Given this list of marker genes Npm1, Brcc3, Ppp6c, Psmd8, Rcc2, Ubc, Nup205, Cdkn1a, Plk4, Kntc1, Mau2, Pole4, Abraxas1, Dynll1, Dync1i1, Nup93, Cenpx, Gtse1, H2bc6, Cep250, Ppp1r12a, Pola2, Cdc45, Terf2, Tubgcp5, Nup153, Anapc1, Haus8, Nup133, Brca1, Smc3, Vrk1, Psmd2, Gins1, H2ac7, Fbxo5, Ube2c, H2bc8, Incenp, Ccna2, Mcm8, Nup58, Dscc1, Kif2a, Pttg1, Rbl1, Nup155, Cenpi, Ran, Terf2ip, Hmmr (hyaluronan mediated motility receptor (RHAMM)), Prim1, Taok1, Psma3, Tubb1 (NCBI Gene Id 72817), Prkaca, Cdc25b, Haus6, Tubb6, Nme7, H4c17, Haus5, Nup62, Tert, Smarca5, H2ac12, Ofd1, H2ac18, Nup85, Bub3, Ncapg, H2ac19, Cdc16, Cep70, Mdm4, H3c7, Cks1b, Nudc, Cdc26, Dync1h1, Ppp2r5e, Pds5b, Cep63, H2bc21, Fbxl18, Ppp2r2a, Gorasp2, Rfc3, Hdac8, Cdc7, H3f3b, Anapc2, H2ac6, Nup43, H4c8, Cdca5, Ska2, Cep57, Cdc27, Haus7, Cables1, Psmc4, Cenpe, Tuba3a (tubulin, alpha 3A), Nup98, Cenpw, Ube2e1, H4c2, Eml4, Kif18a, Ccna1, Wapl, Psmc5, Aurka, Wee1, Rfc5, Cenph, Ccnb1, Nup214, Brip1, Clspn, Mapk3, H2bc26, Lpin2, Hdac1, Ywhag, Nek9, Kif2c, Phf20, H2aj, Mis12, Ppp2r5c, Nup42, Exo1, Aurkb, H2ac20, Anapc15, Hsp90ab1, Csnk2a2 (NCBI Gene Id 97446), Zw10, H2ax, Ppp2r1a, H3c15, Ist1, Cdc6, Ccnb2, Skp2, Ckap5, Nhp2, Terf1, Herc2, Cenpu, Cep131, Mcm2, H2ab3, Dync1i2, Fkbpl, Cep72, Cdk1, Haus1, Ccnd1, Mcm3, Banf1, Lin54 (lin-54 DREAM MuvB core complex component), Ubb, Fbxl7, Seh1l, Rbx1, Wrn (NCBI Gene Id 22427), Cdk2, Rfc4, Zwint, Mcm5, Ube2d1, Cetn2, Psmd7, Ndel1, E2f2, Cenpc1, Rnf8, Ranbp2, Rtel1, Rbbp7, Akt2, H2bc12, Pias4, Ccp110, H2bc22, Rb1, Pold4, H2bc24, Rmi1, Pole, Chek1, Pold1, Ppp2ca, Lmnb1, Psmd12, Atrip, Uba52, Csnk2b, Rbbp8, Abl1 (NCBI Gene Id 98922), Mis18bp1, Akt3, Chmp3, Pkmyt1, Psmd3, H3c6, Akt1, Psma5, Anapc16, Orc6, Psma6, Chmp2b, Vps4a, Spast, E2f3, Tuba1a, Orc5, Skp1 (NCBI Gene Id 76591), Cenpp, Tpr, Esco2, H3c4, Psma1, Rad9b, Rab1a, Anapc5, Tubgcp6, Oip5, Ppp2r5a, H2ac15 (H2A clustered histone 15), Cnep1r1, Sfn, Haus2, Fbxw11, H3c3, H3c13, Ahctf1, Mcm10, Ppp2r1b, Rfc1, H2ac4, Nup107, Ncapd3, H2bc4, Ankle2, Ten1, H4c18, Gmnn, Tubg2, Nup37, Lbr, Nsl1, Ube2n, Rfc2, Obi1 (NCBI Gene Id 72486), Dync1li1, Pold3, Ppp2cb, Mnat1, Psmb3, H2ac8, Tubb2a, Orc2, Kif20a, Optn, Uba52rt, Smc1a, Cdk7, Prim2 (NCBI Gene Id 98311), H2bc14, Ppp1cb, Nup160, Cenpm, Ccnd2, Ccne2, Firrm, Bub1, Blzf1, Tubg1, Tuba8, Dctn2, Sfi1, Ruvbl1, Pif1, Chek2, Rpa2, Psmd6, H4c9, Jak2, Dyrk1a, Sdccag8, Hsp90aa1, Blm, Akap9, Kif23 (NCBI Gene Id 97568), Haus3, Cdt1, Ywhaq, Dynll2, Lpin3, Chmp4b, Gins4, Orc1, Ninl, Spc24, Rsf1, Kpnb1, Arpp19, Mcm4, H3c8, Psmc1, Alms1, H3c2, Mdm2, Pafah1b1, H2ac13, Cenpa, Psmb6, Babam2, Rcc1, Smc4, Mad1l1, Ywhaz, Ppme1, Ajuba, Rab1b, Cdc23, Aaas, Cdc25c, Ube2s (ubiquitin-conjugating enzyme E2S), Clasp2, Cenps, Babam1, Chtf18, Csnk2a1, Dctn1, Psmd1, Tfdp1, Emd, Cenpk, Clip1, Prkcb, Psma7, Tubgcp2, Psmd13, Lin37, Cenpt, Ppp1r12b, Mcm7, H3f3a, Clasp1, Mad2l1, Orc3, Lin52, Hjurp, Cep78 (NCBI Gene Id 77136), Mcph1, Trp53bp1, Plk1, Mzt1, Ndc80, Cdkn1c, Dmc1, Cep290, Gins3, Nek2, Sirt2 (sirtuin 2), Ncapg2, Numa1, Psma2, Atm, H4c1, H4c12, Sgo2a, Rmi2, Lmna, Ncaph, Nup35, Pcm1, Ccne1, Spdl1, Psmc3, Cdc25a, Cenpo, Pds5a, Csnk1e, Lig1, Mis18a, Kat5, Cdca8, Rps27rt, H2ac10, Pola1 (polymerase (DNA directed), alpha 1), H2bc23, H2ac23, Rad21, Psmb4, Actr1a, Ppp2r5b (protein phosphatase 2, regulatory subunit B', beta), Lyn (LYN proto-oncogene, Src family tyrosine kinase), Rab8a, Psmb2, Cep164, Daxx, Cenpj, Stag2, Set, Cdk11b, H2ab2, Rae1, Dbf4, H4c6, Nop10, Nup210, Psmd11, Tubb5, Haus4, Ywhab, Rpa1, Fen1 (NCBI Gene Id 14156), Nipbl, Sec13, Rbbp4, Shq1, E2f5, Ube2i, Cdc14a (NCBI Gene Id 229776), Cdc20 (NCBI Gene Id 98038), Ccnd3, Ska1, Cep135, Ctdnep1, H3c1, Tubal3, Rbm39, H3c11, Tubgcp4, Psmb5, Psmb1, Lin9, Psmb7, Atrx, Hus1, Sgo1, Nup88, Chmp6, H3c14, Chmp4c, Cdk4, Ssna1, H2bc3, Chtf8, Trp53 (transformation related protein 53), Odf2, H2bc15, Ube2v2, Tpx2, Pom121 (NCBI Gene Id 97245), Zfp385a, Espl1, H4c14, Fzr1, Dkc1, E2f4, Cdkn2b, Fignl1, Bard1, Gar1, Ywhah, Nuf2, Chmp2a, Acd, Smc2, Cep192, Pcna, Anapc7, Chmp7, Rad1, Bora, Cdk6, H2ac22, Nup50, Csnk1d, Anapc10, Rad50, Cc2d1b, Cul1, Rpa3, Ptk6, Pole3, Anapc11, Nsd2, Ncapd2, Rad51, Esco1, Tubb3, Wrap53 (WD repeat containing, antisense to Trp53), Psmd14, Nup188, Ndc1, Zwilch, E2f1, Ncaph2, Cdkn1b, Tuba1c (NCBI Gene Id 22146), Psmc6, Tuba3b, Vrk2, Tubb4b, Rhno1, Ticrr, Ctc1, H4c16 (H4 histone 16), Dctn3, Ankrd28, Tubb2b (tubulin, beta 2B class IIB), Nde1, Pmf1, H2ab1, Sumo1, Pot1a, H2az2, Nedd1, H2bc13, Cenpn, Dna2, Mastl, H3f4, Uimc1, Rps27, Tuba4a, Cep76, Src (NCBI Gene Id 99351), Tuba1b, Cenpq, Topbp1, Rangap1, H2bc9, Ppp1cc, Cop1, Ppp6r3, H2ac24, Gorasp1, Mapre1, H4c3, Orc4, Cenpl, Tubgcp3, H3c10, Adrm1, Cep43, Rnf168, Ppp2r3d, Mcm6, Mre11a, Cenpf, Rad17, Ccnh, Pole2, Lcmt1, Stag1, Psma4, Dync1li2, Spc25 (SPC25, NDC80 kinetochore complex component, homolog (S. cerevisiae)), Golga2, Dsn1, Cdk5rap2, B9d2, Bub1b, H2bc7, Anapc4 (NCBI Gene Id 67924), Rps27a, H2ac11, Top3a, Tubb4a, Rab2a, Phlda1, Nup54, H4c11, H2bc11, Ywhae, Pold2, Rad9a, Mzt2, Ppp2r5d (protein phosphatase 2, regulatory subunit B', delta), Stn1, H2bc1 (NCBI Gene Id 319177), Cep41, Mdc1, H4c4 (NCBI Gene Id 319156), Mapk1, Kif2b, Itgb3bp, Cep152, Foxm1, Xpo1, Gins2, Ercc6l, Nbn, Rbl2, Psmc2, here is a description of the gene set: species: Mus musculus Mouse Gene Set: REACTOME_CELL_CYCLE Cell Cycle